The following is a description of a gene set: from publication Jinesh GG, Kamat AM (PMID 28855211) Apoptosis is a process that kills cells. However, cancer stem cells find ways to escape death after commencement of apoptosis. One such mechanism is blebbishield emergency program, in which the apoptotic cancer stem cells first undergo apoptotic body formation but then reassemble apoptotic bodies with main body (nuclei containing) of the apoptotic cells to form spherical to elongated structures called blebbishields. Blebbishields in turn are capable of blebbishield-blebbishield fusion to form transformed stem cell spheres (transformation phase) and then give rise to individual cancer cells from spheres (exit phase). Blebbishields are also capable of fusion with immune cells. The resulting hybrids are called PBSHMS cells in this study. We did microarray analysis of live RT4P cells, and hybrid PBSHMS cells. This data set is a comparison of RT4P cells, and hybrid PBSHMS cells and the gene list includes the genes that are upregulated in blebbishield-immune cells hybrids (PBSHMS). A separate set is provided for downregulated gene list too. species: Homo sapiens Human Gene Set: JINESH_BLEBBISHIELD_TO_IMMUNE_CELL_FUSION_PBSHMS_UP Genes Upregulated in PBSHMS (RT4 blebbishield-to-immune cell fusion), and this is the list of marker genes: ANKRD1, KRT18P55, NETO1, PLIN5, PBX4, IL1A, BLCAP, THBS1, TMEM64, GHR (NCBI Gene Id 2690), CNIH1, C12orf76, KRT16, EPAS1, PIEZO1, VMP1, PRAG1, ASPH, SLC20A2, KIAA1671, CD151, NFE2L3, TACC1, DGCR2, NABP1, TNFRSF19, GJB6, TIMP2, PTCHD1, EMX2, IGFBP5, ITGAV, HSPA8, ARL14, CRCT1, GADD45B, UGGT2, HK2, INPP4B, CYP2S1, TRIAP1, TAGLN, MYH9, ENDOD1, SMAGP, ALDH3A1, MACF1, TMEM191A, ZNF219, UPK2, BAX, ACTB, RANBP1, BCYRN1, RHOBTB3, PODXL (podocalyxin like), PLAAT3, ANGPTL4, MAPT, CAPRIN2, SBF1, PISD, KIAA1549L, RPL29, S100A10, EPHA2, PRSS23, CORO1C, DSG2, H2BC5, TXNDC11, PLS3, NUAK1, SYTL4 (synaptotagmin like 4), SRSF5, FBXO22, XPC, S1PR3, HSP90AA1, EEF1A2, HLA-A, CLIC3 (NCBI Gene Id 9022), ZDHHC8, PALLD (NCBI Gene Id 51653), ZFP36L2, DYNC1H1, CLIP1, FBLN1, BCL2L1, COTL1, ACTN4, F2R, TM7SF3, ZYX, CCDC14, ZNF175, JUN, SLC9A2, TRIM6, SLC12A4, PCDH7 (NCBI Gene Id 90855), TPM1, CRKL, GABBR1, SLC7A2, EGFR, SMAD3, TIMP3, ATP1A1, PATJ, GALNT1, SEPTIN3, CDC42EP3 (NCBI Gene Id 10602), ZMAT3, SYT9, SERINC1, SPTSSB, PLAC8 (NCBI Gene Id 95621), TUBB6, SPTBN1, HOXC13, FAM234B (family with sequence similarity 234 member B), KLF6, LARP4B, H2BC12L, KITLG, TUBGCP6, KDM6A, XYLT1, ADGRG6, DKK3, SLC35G1, FLRT3, MRPL40, GBP1, GADD45A, CLTB (NCBI Gene Id 1212), CCN1, CTNNB1, TUBB3, ALDH1A3, UBE2E1, CENATAC, PDPK1 (3-phosphoinositide dependent protein kinase 1), HSPB8, C15orf39, TYMSOS, ADAM9, TRAK1, TNFRSF12A, DMWD, KCNN4, H2AC18, ATOH8, UPK1B, GSN, MIR503HG, PLOD2, INSIG2, ST3GAL4, RRAS2, HS6ST2, HSPA4L, H2BC11, DLC1 (DLC1 Rho GTPase activating protein), MSX2, SPINT1, PLCD3, ATP2A2, COPG2, PAM, TANC1, WWC1, UBE2E2 (ubiquitin conjugating enzyme E2 E2, NCBI Gene Id 7325), FBXO32, MED15, FPR3, SLC20A1, CTSZ, EPPK1, USB1, APLP2, SLC16A7, KRT7, ADCY6, DIAPH1 (NCBI Gene Id 1729), CABLES1, ATP11B (ATPase phospholipid transporting 11B (putative)), PLXNA1, TIGAR, CST4, NRBP2, TMBIM1, TANGO2, SPINK1, CD59, RAC1, AHNAK, CYB5R1, KIF1C, FAM13A, ITGB1, PLXNB2, EGLN3, ESS2, AAK1, CA2, SCN9A, BID, SPOCK1, FRMD3, BSG, DACH2, FHL2, MAPK1, FLNB, DGCR8 (DGCR8 microprocessor complex subunit), PLSCR3, BRD1, RTL10, RP2, LMF2, HEBP1, DUXAP9, CAVIN1, IKBIP, LRP5L, TNFRSF10B, RHBDF1, ACKR2, SLIT3, GPRC5A, ACTA2, CNN2, INPP5D, HIC2, RPL7A, KRT17, LIMCH1, RSRP1, UPK3A, SNRPD3, TERF1, PPL, SNAP29 (synaptosome associated protein 29), SRPX, KRT17P3, EGR1, DKK1, IGF2BP3 (insulin like growth factor 2 mRNA binding protein 3), TGFA, ICA1 (NCBI Gene Id 3382), IGF2BP2, FYN, FAM107B (family with sequence similarity 107 member B), COMT, YDJC, SMYD2, H2BC12, CRYBB2, MACROH2A1, BASP1, PPM1F, CTXN1, BCAS1, OXR1, TRIM22, CHKB, TMEM45B, FGD3, WDR1, SLC4A11, SELENOT, CYFIP2, EPB41L3, INIP, VAPA, CLPTM1L, TOR3A, TOP3B, KRT80, MPRIP, CAV2, CPA4, SNX31, H2AC6 (H2A clustered histone 6), CITED2, COL5A2, PLXNA3, SVIL, TSC22D2, PLA2G2A, C19orf33, SERPINH1, RRM2B, MATN2, SPAG9, LZTR1, CHKA, MYLK, LHFPL6, MSI2, ACTG2, SDF2L1, C1QTNF6, UPK1A, VPS13A, NAV2, ZNF74, ADM, GNAQ, PRRG1, PMEPA1, OLR1, ZNF823, MBOAT7, JUP, SULT2A1, ATP6V1E1 (ATPase H+ transporting V1 subunit E1), PDLIM5, DBN1, KIFC2, NR2F2, CRIM1, PRDX6, CMKLR2, A4GALT, SLC9A7, NIN, TRIO, DUSP10, DUSP4, ENTPD3, ERRFI1, CAV1, PI4KAP2, ELOVL1, NLRP8, RHOC, LAMA5, CTTN, PPP2CB, ANXA2, PPP6R2, VCL, MCM8, TSPAN6, TYMS, PROK2, FAT1, SLC10A3, SLC12A2, ASAP1, ACKR3, QSOX1, CDH2, PRP4K, MICAL2, CUL9, TIGD2, EFEMP1, AEN, GTF2I, DCP2, MAN2A1, SYTL2, ACTN1, VKORC1, ETFB, ZBED4, SPATA18, HMOX1, ADGRF1, SASH1, ADAM23, MYADM, ADRB2, GJB2, LHFPL2, OSBPL1A, ANXA3, BICC1, PI4KA